Given this list of marker genes SLC38A3, MRM2, POLG (NCBI Gene Id 5428), TWNK, PCDH19, SCN1A, SCN2A, GABRG2, MAST3, GABRA1, BRAT1, SCN1B, SCN9A, COQ8A, TEFM, PDE2A, PDSS2, here is a description of the gene set: Human Gene Set: HP_FOCAL_MOTOR_STATUS_EPILEPTICUS Focal motor status epilepticus Status epilepticus with focal motor signs originating within networks limited to one hemisphere. Involves musculature in any form. The motor event could consist of an increase (positive) or decrease (negative) in muscle contraction to produce a movement. species: Homo sapiens